Given this list of marker genes GRM1, TRPC3, ITPR3, GNAQ, PLCB1, PRKCG, PLCB2, ITPR1, PLCB3, PLCB4, ITPR2, here is a description of the gene set: Mutation-activated PRKCG to mGluR1-TRPC3 signaling pathway. Pathway ID: N00956. Pathway type: Variant. Pathway class: nt06462 Spinocerebellar ataxia. Pathway Definition from KEGG: Glutamate -> GRM1 -> GNAQ -> PLCB -> IP3 -> ITPR -> Ca2+ -> PRKCG* -| TRPC3 species: Homo sapiens Human Gene Set: KEGG_MEDICUS_VARIANT_MUTATION_ACTIVATED_PRKCG_TO_MGLUR1_TRPC3_SIGNALING_PATHWAY